The following is a description of a gene set: Crumpled ear species: Homo sapiens Human Gene Set: HP_CRUMPLED_EAR Distortion of the course of the normal folds of the ear and the appearance of supernumerary crura and folds., and this is the list of marker genes: FBN2, MESD, UBAP2L (ubiquitin associated protein 2 like, NCBI Gene Id 9898), TWIST1, FBN1, LONP1